Given this list of marker genes VPS33B, PLOD2, P3H3, P3H4 (NCBI Gene Id 10609), JMJD6, PLOD3, PLOD1 (NCBI Gene Id 5351), VIPAS39, here is a description of the gene set: Human Gene Set: GOBP_PEPTIDYL_LYSINE_HYDROXYLATION The hydroxylation of peptidyl-lysine to form peptidyl-hydroxylysine. studied in species Homo sapiens